The following is a description of a gene set: Vestibular schwannoma A vestibular schwannoma (also known as acoustic neuroma, acoustic neurinoma, or acoustic neurilemoma) is a benign, usually slow-growing tumor that develops from the VIIIth cranial nerve supplying the inner ear. Human Gene Set: HP_VESTIBULAR_SCHWANNOMA species: Homo sapiens, and this is the list of marker genes: KARS1, SMARCB1, KRIT1, CCM2, COQ6, SPRED1, LZTR1, PIK3CA, PDCD10, HRAS, NF2